Given this list of marker genes STXBP1, SLC7A13, TNF, GNAT2, ARL6IP1, PSEN1, PER2, SLC38A6, SLC1A2, SLC17A6, SLC3A1, TTYH3, RAB3GAP1, SLC25A18, ITGB1, SLC1A1, KMO, ATP1A2, EPM2A, CLN8, VPS54, SLC38A2, SLC1A7, SLC1A3, SLC25A22, SEPTIN2, SLC25A13, SLC7A11, TTYH2, KCNJ10, TTYH1, SLC25A12, ABCC8, SLC17A7, GRM1 (glutamate metabotropic receptor 1), DTNBP1, SLC17A8, NF1, NTSR1 (NCBI Gene Id 4923), KCNJ8, SLC1A4, ARL6IP5, PRAF2, SLC1A6, here is a description of the gene set: Human Gene Set: GOBP_L_GLUTAMATE_IMPORT species: Homo sapiens The directed movement of L-glutamate, the L-enantiomer of the anion of 2-aminopentanedioic acid, into a cell or organelle.